Given this list of marker genes GBA2, PRKAA1, MIR195, B3GALT2, MIR16-1, UGCG, GAL3ST1, GBA1, PRKCD (NCBI Gene Id 5580), SCARB2, GBA3, FA2H, B4GALT3, ST6GALNAC6, UGT8, GLA, GALC, LCT, MIR127, ST6GALNAC3, B3GALT1, here is a description of the gene set: The chemical reactions and pathways involving glycosylceramides, any compound formed by the replacement of the glycosidic hydroxyl group of a cyclic form of a monosaccharide (or derivative) by a ceramide group. Human Gene Set: GOBP_GLYCOSYLCERAMIDE_METABOLIC_PROCESS studied in species Homo sapiens